The following is a description of a gene set: Human Gene Set: GOBP_DEPYRIMIDINATION The disruption of the bond between the sugar in the backbone and the C or T base, causing the base to be removed and leaving a depyrimidinated sugar. species: Homo sapiens, and this is the list of marker genes: NTHL1, NEIL2, MBD4, OGG1, SMUG1, TDG, UNG, NEIL1